Given this list of marker genes ACVR1B, CRIPTO3, CFC1, DAND5, NODAL, LEFTY1, ACVR2A, LEFTY2, ACVR2B, CRIPTO, CER1, ACVR1C, here is a description of the gene set: Mature NODAL can form heterodimers with LEFTY1, LEFTY2, or CERBERUS. The heterodimers do not activate the NODAL receptor. LEFTY1 and LEFTY2 also bind CRIPTO and CRYPTIC coreceptors and prevent them from interacting with other components of the NODAL receptor. By these mechanisms LEFTY1, LEFTY2, and CERBERUS negatively regulate NODAL signaling. part of: Signaling by NODAL species: Homo sapiens Reactome Pathway: Regulation of signaling by NODAL